Given this list of marker genes NACA4P, ADARB1 (adenosine deaminase RNA specific B1), DUSP1, DYRK1A, TARP, IL2RB, BTN3A1, LEPROTL1, RAD51B, TSPYL4, DNAJB1, RPL19, CAMK2G, MZT2A, RPS15, DSC1, HNRNPA1, CD6, MOAP1, STK17B, YES1, DKC1, TTPAL, SAP30L-AS1, VAMP2, PIM2, EHD1, ADPRM, NXT1, BACH2, GYPC, PDE4B, RLN2, TMEM131L, RPF1, PTPRCAP, HNRNPUL1 (heterogeneous nuclear ribonucleoprotein U like 1), EIF3E, INTS15, CTDSP1, SYNE2, HIVEP2, RETREG1, CCNB1IP1, IL11RA, IKZF5, JADE2, CD5, EEIG1, FGF9, CYTH1, CCDC88C, RPL36, TUT4, PSMD4, MYLIP, CD160, PRIM1, STK38, CLEC2D, EIF3F, NOSIP, PMS2P5, PTPN4, ICAM2, TGIF2 (NCBI Gene Id 60436), CCDC59, GPRASP1, FOXJ3, CDC7, RPS25, UBA52, GCFC2, SLC16A7, CX3CR1, GPR18, ARHGAP5, ZAP70, HNRNPD, INPP4B, IPCEF1, AGAP1, MLLT11, ZFTA, NCK2, UBA7, PBXIP1, DPH5, ITM2A, IRF3, KLRG1, CD28, FLT3LG, BICRAL, IL32, PRKCQ, PVRIG, AATF, GPR171, ZBTB25, ETS1, UXT, LIME1, OGG1, WRAP53, RPL28, RRAS2, RPL6, LSR, PCSK7, CD2, SERPINB9 (NCBI Gene Id 5272), PDCD4-AS1, NR3C2, ACD, PIP4K2A, IKZF1, RPS9, ZNF430, ADRB2, RABAC1, GCDH, CACNA2D2, VNN2, ICOS, NIPAL3, RPL30, LTBP3, TBC1D4, EIF2D (NCBI Gene Id 1939), MLLT3, EIF4B, NRF1, TPT1P8, LINC00623, DDX60, BCL2, HOPX, RPL35A, TXK, NKG7, AKTIP, RBM10, UBASH3A, MZT2B (NCBI Gene Id 80097), BTN3A2, LTB, ZNF529, RNF126, DGKD, PIGA, MAGED2, DOCK9, PLEKHB1, BCL11B, EIF3H, EZR, SNRPD2, CDC25B, ITPR3, CCNG1, RPL14, SP110, RPL35, NCALD, ABCD2, INPP4A, ALDOC, CYFIP2, PRKCZ, APOBEC3G, SIDT1, ATP8A1, GALT, PRF1 (perforin 1), MATR3, TSC22D3, GVINP1, SNRK, EEF2, MAPRE2, TCF7, HLA-F, LINC00342, TRANK1, VPS51, STAT5B, LRBA, CLUHP3, RPL10L, MEX3C, GZMA, GRAP2, CD7, KMT2A, PRR5, CD3E, CCDC25, PASK, GP5, here is a description of the gene set: studied in species Homo sapiens Immune cell-specific expression is one indication of the importance of a gene's role in the immune response. In order to identify such patterns, we set out to broadly profile gene expression in a variety of immune cells. Genes up-regulated in comparison of naive CD8 T cells versus unstimulated dendritic cells (DC). from publication Abbas AR, Baldwin D, Ma Y, Ouyang W, Gurney A, Martin F, Fong S, van Lookeren Campagne M, Godowski P, Williams PM, Chan AC, Clark HF (PMID 15789058) Human Gene Set: GSE22886_NAIVE_CD8_TCELL_VS_DC_UP